Given this list of marker genes Nfrkb, Mre11a, Ino80d, Hnrnpd, Mapk1, Ppp1r10, Tnks2, Potefam3b, Ptges3, Map3k4, Nbn, Atm, Tnks, Tinf2, Pkib, Sirt6, Pot1a (protection of telomeres 1A), Actr8, Gch1, Ino80c, Actl6a, Potefam3a, Atrx, Cct8, Nek7, Nvl, Slx1b, Ino80b, Actr5, Myc, Klf4, Terc, Xrcc5, Cct2, Cct6a, Mapk15, Ctnnb1, Mapkapk5, Hnrnpa2b1, Mapk3, Yy1, Ankrd66, Map2k7, Tfpt, Nek2 (NCBI Gene Id 98226), Cct5, Cct3, Rad50, Terf2ip (telomeric repeat binding factor 2, interacting protein), Tcp1, Wrap53, Fbxo4, Wnt3a, Ruvbl1, Terf1, Uchl5, Mcrs1, Pnkp, Cct7, Hmbox1, Naf1, Parn, Dhx36, Nabp2, Acd, Ercc1 (excision repair cross-complementing rodent repair deficiency, complementation group 1), Atr, Ino80, Gnl3, Pot1b, Terf2, Rtel1, Dkc1, Cct4, Slx4, Prkcq, Ruvbl2, Aurkb, Pml, here is a description of the gene set: Mouse Gene Set: GOBP_POSITIVE_REGULATION_OF_TELOMERE_MAINTENANCE studied in species Mus musculus Any process that activates or increases the frequency, rate or extent of a process that affects and monitors the activity of telomeric proteins and the length of telomeric DNA.